The following is a description of a gene set: A compound muscle action potential (CMAP) is a type of electromyography (EMG). CMAP refers to a group of almost simultaneous action potentials from several muscle fibers in the same area evoked by stimulation of the supplying motor nerve and are recorded as one multipeaked summated action potential. This abnormality refers to a greater than normal decrease in the amplitude during the course of the investigation. species: Homo sapiens EMG: decremental response of compound muscle action potential to repetitive nerve stimulation Human Gene Set: HP_EMG_DECREMENTAL_RESPONSE_OF_COMPOUND_MUSCLE_ACTION_POTENTIAL_TO_REPETITIVE_NERVE_STIMULATION, and this is the list of marker genes: CHRNE, DOK7, SYT2, ALG2, RYR1, CHRNA1, SCN4A, MYL1, MUSK, LRP4, AGRN, LAMB2, CHRND, NOTCH2NLC, VAMP1, GMPPB, ALG14 (ALG14 UDP-N-acetylglucosaminyltransferase subunit), COL13A1, CHRNB1, BIN1, TEFM (transcription elongation factor, mitochondrial), GFPT1, CHAT, TTN, SLC5A7, DPAGT1, SPEG, COLQ, AK9, RAPSN